The following is a description of a gene set: Cytokines mediate cell-cell communication in the immune system and represent important therapeutic targets. A myriad of studies have highlighted their central role in immune function, yet we lack a global view of the cellular responses of each immune cell type to each cytokine. To address this gap, the authors created the Immune Dictionary, a compendium of single-cell transcriptomic profiles of more than 17 immune cell types in response to each of 86 cytokines (>1,400 cytokine-cell type combinations) in mouse lymph nodes in vivo. A cytokine-centric view of the dictionary revealed that most cytokines induce highly cell-type-specific responses. For example, the inflammatory cytokine interleukin-1β induces distinct gene programmes in almost every cell type. A cell-type-centric view of the dictionary identified more than 66 cytokine-driven cellular polarization states across immune cell types, including previously uncharacterized states such as an interleukin-18-induced polyfunctional natural killer cell state. from publication Cui A, Huang T, Li S, Ma A, Pérez JL, Sander C, Keskin DB, Wu CJ, Fraenkel E, Hacohen N (PMID 38057668) species: Mus musculus Mouse Gene Set: CUI_T_CELL_CD8_TSLP_RESPONSE_UP Genes positively differentially expressed in cell type: CD8+ T cell upon treatment with cytokine: TSLP in mouse lymph nodes in vivo., and this is the list of marker genes: Ranbp1, Jaml, Ccnd2, Dkc1, Phgdh, Pa2g4, Eif5a, Srm, Eif4a1, Ncl, Anp32b (NCBI Gene Id 67628), Rexo2, Igfbp4, Npm3, Socs1, C1qbp, Nudc, Gnl3, Ppp1r14b, Vim, Ran, Bcl2, Eno1, Nop56, Gar1